The following is a description of a gene set: studied in species Mus musculus Any process that activates, maintains or increases the rate of pinocytosis. Pinocytosis is the process in which cells take in liquid material from their external environment; literally 'cell drinking'. Liquid is enclosed in vesicles, formed by invagination of the plasma membrane. These vesicles then move into the cell and pass their contents to endosomes. Mouse Gene Set: GOBP_POSITIVE_REGULATION_OF_PINOCYTOSIS, and this is the list of marker genes: Actn4, Ppt1, Appl2, Axl, Ankfy1, Cdc42, Cln3, Appl1